Given this list of marker genes Ptpn1, Uba52rt, Irf9, Ubb, Ptpn6, Ifna4, Ifna7, Ifna6, Ifna13, Ifnab, Kpna1, Ifna2, Ifna15, Ifna5, Rps27a, Socs3, Ifna16, Ptpn11 (NCBI Gene Id 72646), Ifna11, Ifna12, Rnasel, Stat2, Ifna1, Ifnar2, Ifna14, Uba52, Usp18, Ifnb1 (interferon beta 1, fibroblast), Ifnar1, Socs1, Kpnb1, Ubc, Abce1, Tyk2, Ifna9, here is a description of the gene set: Interferon alpha/beta signaling Mouse Gene Set: REACTOME_INTERFERON_ALPHA_BETA_SIGNALING studied in species Mus musculus